Given this list of marker genes Htr2c, Tnfsf11, Ecrg4, Clcf1 (NCBI Gene Id 56708), Apln, here is a description of the gene set: Mouse Gene Set: GOBP_REGULATION_OF_CORTICOTROPIN_RELEASING_HORMONE_SECRETION studied in species Mus musculus Any process that modulates the frequency, rate or extent of corticotropin-releasing hormone secretion.